The following is a description of a gene set: from publication Chen Y, Wang X (PMID 31504780) Genes predicted to be targets of miRBase v22 microRNA mmu_miR_465c_5p in miRDB v6.0 with MirTarget v4 prediction scores > 80 (high confidence targets). studied in species Mus musculus Mouse Gene Set: MIR_465C_5P, and this is the list of marker genes: Vta1 (vesicle (multivesicular body) trafficking 1), Pof1b, Smarca1, Btbd1, Phf3, Foxb1, Pank3, Lrrtm4, Parp8, Cxadr, Casp8, Samt1 (NCBI Gene Id 78092), Tecrl (trans-2,3-enoyl-CoA reductase-like), Lrrtm2, Thoc2, 1110004F10Rik, Kpna3, Tmtc3, Esp18, Efcab14, Ccdc85a, Mmp24, Kitl, Nup62, Stc2, Efhc1, Card19, Tspan13, Hopx, Mlx, Cox16, Tiprl, Itgb3bp, Sqor, Sbno1, Nhs, S2bpcox16, Samt1b, Snrpg, Wnt5b, Arrdc3, Slc25a22, Pla2g3, Alg6, Secisbp2l, Zfp747, Mcm8, Gria4, Gosr1, Tspan14, Pak1, Ubl3, Gmcl1, Tle4, Depdc7, Ptk2, Tex12, Avl9, Trib2, Pfkfb2, Pwwp3b, Dmrta1, Eny2, Ap3s1, Oat, Oaz1, Dgkb, Stag2, Foxa2, Mpp4, Rbfox1, Snx13, Zdbf2, Fbxl17, Ltn1, Rab14, Msl3, Strap, Lrrc57, Rnls, Zfp729b, Hspa4, Fam76b, Osbpl8, Actr2, Krt6a, Irf2, Ehd4, Ms4a2, Syde2, Esp34, Rnf113a2, Naaladl2, Unc93a, Csn1s1, Lin28b, Susd6, Ugt2a3, Lin9, Phf8, Cyp4a31, Batf, Adam28, Irf6, Osbpl1a, Prkcd, Hand1, Cpne8, Mat2b, Fam185a (NCBI Gene Id 330050), Mpp7, Gucy1a1, Cbx8, Sec11c, Cdkl4, Trappc6b, Mmd, Kndc1, Mdh1, Tjp1, Mogs, Zfp809, B020004C17Rik, Samt1c, Corin, Rsf1, Dip2a, Capn3, Gpr85, Yipf3, Zfpm2, Pex13, Tra2b, Pla2g5, Ranbp3l, Kera, Vwc2, D17H6S53E, Actl6a, Ehmt1, Esp31, Gabra4, Wdfy3, Ptprk, Kcnab1, Septin10, Slc7a11, Txndc5, Ppfibp1, Morn1, Lca5, Noxo1, Mark3, Lyn, Tacc2, Klhl12, Pcdh9, Dpyd, Treml1, Trim30b, Gm10778, Rfx3, Nt5e, Ints5, Smc3, Rev3l, Zfp738, Gucy1a2, Ptbp3, Cyp20a1, Krtap15-1, Trub1, Nudt4, Samd8, Baz2a, Mtdh, Socs6, Fbxo4, Hs3st3a1, Cpeb2, Ube2w, Ccdc87, Samt1d, Lhcgr, Fgd4, Ube2s, Tti2, Alg14, Scn1a, Naa30, Armcx5, Cd9, Gm16445, Adhfe1, Gpr21, Gins3, L2hgdh, Gabrg1, Glcci1, Cfap20, Exph5, Ythdc2, Gabra6, Kcnj2, Zfp60, Sim1, Cngb1, Fnip1, Srrm1, Napepld, Jam3, Acbd5, Entr1, Boc, Cdh5, Celf3, Zmiz1, Psmd11, Myo19, Il1rap, Epm2aip1, Crebrf, Slco2b1, Pigp, N4bp1, Zfp248, Sox6, Cyp2j6, Ccdc88a, Sgpp1, Ankra2, Aplf, Chic1, Tcf12, Acadsb, Cntn3, Nhlh2, Hnrnpr, Nup205, Sypl1, Zfp148, Serpinb11